Given this list of marker genes FBXO16, SENP6, HMGB1, DLC1, LINC03108, CCDC110, TNRC6C (NCBI Gene Id 57690), SPAG9, STX16-NPEPL1, EGFLAM, EVI2A, DPYD-AS2, BUB1B, BAIAP3, LRIG1, BHLHA15, DHX34, TRAV13-2, LDAH, NFX1, ATP6V1G1P6, CAMK2D, DEFB128, WWP1, TFAM, PNRC1-DT, C1orf74, NDUFB4P4, PTK2, PCBP1-AS1, CTSO, OR6B3, STAU2, RAP1GDS1, KCNJ10, MIR7-3, PLCE1, GLRA1, SLC44A4, BRCA2, FGFR4, PYM1, PDCD4-AS1, LINC01304, LAMP1, YTHDF2, ZYX, PSMD4, FAM131B-AS2 (FAM131B antisense RNA 2), GLTPD2, INO80B-WBP1, RNVU1-19, TRIM38, LYSMD1, RNA5SP60, MUC13, CFTR, MIR7-3HG, MIR626, NCAPD2, ARNT2, RNU6-1163P, CLK4, HMGB3P8, ALK, PNRC1, LONP2 (NCBI Gene Id 83752), SIRT1, NLRP4, CPEB1-AS1, MIR3188, CENPC (NCBI Gene Id 1060), GABRA5, SNORA70D, OR13D3P, TGFBI, CDKN2AIP, ATM, MCM8-AS1, NRXN3, HTR5A, DHRS2, SLC8A1-AS1, RPL5P21, TLR3, SNAP25-AS1, INO80B, PDXK, SQSTM1, RNVU1-15, MIRLET7D, RUNX1, AP5Z1, TLR10, LNCATV (lncRNA negative regulator of antiviral signaling), ARHGEF7, CPEB1, SCAT8, CPNE3, GCAT (NCBI Gene Id 23464), ANKRD66, TSHB, PKN2-AS1, CCNL1, RGS18, BABAM1, GNAS, DNAJB4, GET4, CRLS1, LINC00877, IKZF2, MEF2C, ENC1, LINC01719, LINC01132, SLC7A11, RNU5A-1, CPXM2, RNVU1-30, VMP1, METTL14, MIR6865, SCNM1, SMG6, MCC, PGK1, DLG1, CELSR1, EYS, EEF1A1, POR, KLF4, ATAD2B, RNU6-896P, CLEC4A, CMC1 (NCBI Gene Id 152100), NSUN6, ZC2HC1C, SH3TC2, USPL1, RNU6-643P, XIRP2, CLASP1 (cytoplasmic linker associated protein 1), RNVU1-14, JUND, CCDC198, UBE4A, MRPL1, H4C2, MFSD1, VPS13B, METTL14-DT, ATP5MC2P5, GPR33, CPLANE1, LY6G5C, MYO9A, here is a description of the gene set: from publication Yevshin I, Sharipov R, Kolmykov S, Kondrakhin Y, Kolpakov F (PMID 30445619) Human Gene Set: METTL14_TARGET_GENES species: Homo sapiens Genes containing one or more binding sites for (METTL14) in their promoter regions (TSS -1000,+100 bp) as identified by GTRD version 20.06 ChIP-seq harmonization.